The following is a description of a gene set: An intracellular organelle, about 200 A in diameter, consisting of RNA and protein. It is the site of protein biosynthesis resulting from translation of messenger RNA (mRNA). It consists of two subunits, one large and one small, each containing only protein and RNA. Both the ribosome and its subunits are characterized by their sedimentation coefficients, expressed in Svedberg units (symbol: S). Hence, the prokaryotic ribosome (70S) comprises a large (50S) subunit and a small (30S) subunit, while the eukaryotic ribosome (80S) comprises a large (60S) subunit and a small (40S) subunit. Two sites on the ribosomal large subunit are involved in translation, namely the aminoacyl site (A site) and peptidyl site (P site). Ribosomes from prokaryotes, eukaryotes, mitochondria, and chloroplasts have characteristically distinct ribosomal proteins. studied in species Homo sapiens Human Gene Set: GOCC_RIBOSOME, and this is the list of marker genes: MRPL23 (NCBI Gene Id 8046), MRPL13, MRPS18B, MRPS28, RPS29, MRPS21, EEF2, MRPL16, NUFIP2, RPLP1 (NCBI Gene Id 6176), MRPS34, AURKAIP1, RPL18, MRPL24, LZTS1-AS1, MRPL39, RPL39L, MRPS14, MRPL15, RPL29, RPL9, RPL13AP3, MRPL40, TIFAB, DHX29, GSPT1, RPS18, MRPS22, MRPL10, RPS7, MRPL22, RPS23, MRPL14, ZNF598, MRPS6, RPL7A, ZCCHC17, NEMF, MRPL2, MRPS24, RPS20, RPL15, NCK1, RPL39P5, RNA5S1, NSUN3, RPL32, MRPS15, MRPL21, RPL5, MRPL43, RPL24, RPL35A, MRPL35, MT3, RPS19, RPS16, FUBP3, RPL12, OAS1, ABCE1, ASCC3, MRPS12, RPL10L, RPL26, APEX1, ASCC2, RPL10A, MRPL11, RPL8, RNF25, MRPL3, MRPS31, CHCHD1, RRBP1, RPL10, RPL3L, RPL7, RPL17, NPM1, RPLP0P6, RBM3, METAP1, MRPL36, NSUN4, RPS4X, RPL22, RPSA2, RPL4, RPL13A, MRPL33, DNAJC21, MTG1, MRPS16, MRPL58, MRPL41, RPS4Y2, MRPS23, MRPS5, LTN1, MRPL34, MRPS27 (NCBI Gene Id 64948), RPS15, RPS2, MRPL48, RPS27, MRPL53, MTERF4, EIF4G1, MRPL32, MRPL52, MRPL12, RPL34, MRPL51, RPL22L1, RPS9, GADD45GIP1, RNA5-8SN5, SRP68, MRPL1, SF1, RNF10, RPL14, CALR, HSPA14, MRPS9, MRPL44, MRPS11, MRPL38, RPS6KL1, MRPL30, USP10, RPS27L, RPS13, MRPL54, MRPS25, RPL27, RPL18A, RPL37A, RPS12, MRPS26, DAZL, MRPL42, RPS5, LARP4, EEF1A1 (eukaryotic translation elongation factor 1 alpha 1), RPL19, MRPL50, MRPL37, RPS21 (ribosomal protein S21), RPS24, APOD, EIF2AK4, RPS3, RPL23A, RPS25, RPS27A, MRPL47, MRPS7, RNF14, RACK1, RPL36, RPS10, MRPL4, MRPL20, PNPT1, RPL31, MRPL18, PSMA6, MRPS2, RPS14, RPL35, RPL26L1, MRPL19, RPL39, FXR1, MTG2 (NCBI Gene Id 339607), MRPL27, MRPL45, RPS3A, RPL37AP8 (ribosomal protein L37a pseudogene 8), RPL28, RPLP0, MRPS18C, GCN1, RPS8, UBA52, FAU, RPSA, RPL41, RPL11, RPS6, RPS10P5, RPL36A, MRPL17, RPL27A, NR0B1, MRPS30, RPS17, RPL38, RNA5S9, PELO, MRPS17, PTCD3, SERP1, RPL7L1, RPL23 (ribosomal protein L23), EIF2A, MRPS18A, RPS15A, EIF2AK2 (eukaryotic translation initiation factor 2 alpha kinase 2), MRPS35, RPL21, RPL13, DDX3X, RPL36AL, SNCA, MRPL46, MRPL55, RPL30, RPLP2, DAP3, RPL6, RPL3, MRPL57 (NCBI Gene Id 84533), MRPL49, MRPL28, RPS4Y1, MRPS33, RPS26, RPL37, MRPS10, RPS11, MRPL9, ETF1, HBS1L, RPS28